Given this list of marker genes SLC25A25, SLC37A2, SLC37A3, SLC25A23, SLC37A4, SLC25A24, SLC37A1, here is a description of the gene set: studied in species Homo sapiens Human Gene Set: GOMF_ORGANOPHOSPHATE_PHOSPHATE_ANTIPORTER_ACTIVITY Enables the transfer of a solute or solutes from one side of a membrane to the other according to the reaction: organophosphate(out) + phosphate(in) = organophosphate(in) + phosphate(out).